Given this list of marker genes CDYL2, BEND4, NALF1, ZNF365, RALB, UQCRB, GSTA4, URGCP-MRPS24, ARPP21, MTRF1L, RXYLT1, CERT1, SLC22A5, CSDE1, TAL1, KMT2D, TREM1, CMTM4, OXR1, LBR, DLG3, LEMD3, MYCBP2, MTSS1, SYNJ2, ABCD3, CAV1, INAFM2 (InaF motif containing 2), FBXO11, FMR1, CBL, TAFA1, NOS1, TMEM42, STMN2 (stathmin 2), WDFY3, SH2D1A, KPNA4, VPS29, CNR1, REEP1, LUC7L3, RFPL2, UPF2, TSHZ1 (NCBI Gene Id 791257), EMB, PLCG1, DSN1, FOXO1, HSPA13, CERS6, ERP44, DNAJC16, KCMF1 (potassium channel modulatory factor 1), LATS2, SRPRA, SPOCK1, FUT9, LRRC17, NCOA3, SLC5A3, MFF, SPCS2, DUSP8 (dual specificity phosphatase 8), ENPP2, KHDRBS3, PDCD6IP, H6PD (hexose-6-phosphate dehydrogenase/glucose 1-dehydrogenase), SLC39A8, HTR1D, NR3C1, LHX1, FGF14, METTL25, NBPF1, PRDM6, LSM3, HTR2C, C9orf72, UMPS, PTPN1, PAFAH1B2, BNC2, MORF4L2, DKC1, RAB10, TLL2, GCG, ZIC3, MAMLD1, EPM2AIP1, KIF3A, SIDT2 (SID1 transmembrane family member 2), ARL15, AAK1, FYN, PAX6, GID8, NR2F1, PCGF5, ITPRID1, here is a description of the gene set: Human Gene Set: MIR4700_3P Genes predicted to be targets of miRBase v22 microRNA hsa-miR-4700-3p in miRDB v6.0 with MirTarget v4 prediction scores > 80 (high confidence targets). from publication Chen Y, Wang X (PMID 31504780) studied in species Homo sapiens